The following is a description of a gene set: Mouse Gene Set: GOMF_ADENYL_DEOXYRIBONUCLEOTIDE_BINDING Binding to an adenyl deoxyribonucleotide, any compound consisting of adenosine esterified with (ortho)phosphate or an oligophosphate at any hydroxyl group on the deoxyribose moiety. studied in species Mus musculus, and this is the list of marker genes: H1f4, St13, Trex1, Hsp90ab1, Hsp90aa1